The following is a description of a gene set: Human Gene Set: GOBP_3_UTR_MEDIATED_MRNA_STABILIZATION studied in species Homo sapiens An mRNA stabilization process in which one or more RNA-binding proteins associate with the 3'-untranslated region (UTR) of an mRNA., and this is the list of marker genes: MYD88, METTL16, RBM10, MAPKAPK2, RBM24, YBX3, ZFP36, ANGEL2 (angel homolog 2), RBM47, TIRAP, DAZ2 (deleted in azoospermia 2), ELAVL1, NICOL1, RBM38, DAZL, QKI, ARID5A, LARP4B, HNRNPC, DAZ1, DAZ3, TARDBP, MAPK14 (mitogen-activated protein kinase 14), ELAVL4, TENT4B, DAZ4, TENT4A, HNRNPA0, BOLL